Given this list of marker genes CENPL, CACNA1E, ZMYM2, SEPHS2, FSTL3, ABCD4 (ATP binding cassette subfamily D member 4), FBXL6, RANBP2, TEC, H3C1, ACCS, NLRC4, KLF3 (KLF transcription factor 3), NDUFB2-AS1, SEC24D, EXOSC2, KRT80, ATG2B, FOXE3 (NCBI Gene Id 2301), ZNF225, IL1F10 (NCBI Gene Id 84639), CCDC77, AGGF1, ABCA17P, KCTD2, ZNF503-AS1 (NCBI Gene Id 253264), CEMP1, ZNF808, AKAP17A, WT1, POTED, HES2, HERC2, LEFTY1, SNX30, CPSF2, CTRC, GRM2, NRXN3 (NCBI Gene Id 9369), NR2F6, DHFR2, USP32, TMEM223, DPY19L3, ZFYVE16, BLTP3B, OXR1, RNF168 (NCBI Gene Id 165918), KBTBD8, PPIP5K2, YLPM1, CCR2, SNORA71A, OBSCN, MIS18BP1, AK7, ABCC2, PLB1, LINC01348, CABP7, TMEM65, GAS2L3, EEPD1, USP38, GLCE, ZFP30, DFFB, C15orf32, LOH12CR2, ZNF638, STAMBPL1, ZNF804A, PCA3, PHYHIP, VPS37A, TNFRSF12A, CCDC144BP, LINC01015, NPY1R, TMEM132B, SHARPIN, RHOT1, PTPN22, PPDPFL, DOCK7, GPR20, ZNF18, TSNARE1, CSNK1G3, SLC16A1-AS1, HYCC1, SUN1, RGS14, NINL, UBAP2, ZC3H14, CAMSAP1, ZCCHC14, ULK3, SPATA3, ANKRD26, FBXO45, SCGB2A1, SDSL, ZNF514, TRAPPC8, PRAM1, EID2B, STC2, TMEM185A, VEGFD, PWWP2B, RUNX1, SERTAD2, INE1, AP1G2, LBR, DAB2 (NCBI Gene Id 1601), KCNE3, ENSG00000282375, CHAMP1, EDC4, ATP1A1-AS1, TLR1, ELAC2, STARD13, SNX21, SLC26A11, COG6, WDR97, DUSP18, CEP76, C1QTNF1-AS1, NIPBL, NUDT12, GCC2, HAUS6, GMNN, DCDC2, TBC1D15, ISLR, ZNF782, CCSAP, IQCF3, EEIG2, ERCC5 (NCBI Gene Id 2073), SLC23A1 (solute carrier family 23 member 1), COG1, NMUR2, MTM1, FAM78A, NDUFV1-DT, GARRE1, CDK8, CEP97, DYDC1, PBX3, CYP17A1, PLAAT1, WDCP, IMPG1, GSG1L, GSTA4, CCDC14, USP4, DGKD (NCBI Gene Id 8527), DZANK1, NPAT, SIX3, REN, SPOPL, STX6, LINC01116, DIRC3 (disrupted in renal carcinoma 3), NAIP, TTI1, MSS51, PCM1, KMT5B, AKAP5, SETDB2, AP4E1, ZBTB34, TAS2R10, TRIM32, ST6GALNAC5, IGIP, ARHGAP45, SERPINH1, TAS1R1, here is a description of the gene set: studied in species Homo sapiens Genes down-regulated in CD5 T cells at acute infection with LCMV-Armstrong: effectors at day 15 versus memory at day 30. Human Gene Set: GSE41867_DAY15_EFFECTOR_VS_DAY30_MEMORY_CD8_TCELL_LCMV_ARMSTRONG_DN During acute viral infections, naïve CD8+ T cells differentiate into effector CD8+ T cells and, after viral control, into memory CD8+ T cells. Memory CD8+ T cells are highly functional, proliferate rapidly upon reinfection and persist long-term without antigen. In contrast, during chronic infections, CD8+ T cells become “exhausted” and have poor effector function, express multiple inhibitory receptors, possess low proliferative capacity, and cannot persist without antigen. To compare the development of functional memory T cells with poorly functional exhausted T cells, we generated longitudinal transcriptional profiles for each. from publication Doering TA, Crawford A, Angelosanto JM, Paley MA, Ziegler CG, Wherry EJ (PMID 23159438)